Given this list of marker genes Swap70, Polm, Asxl1, Xrcc4, Ccr4, Rnf8, Hmgb1, Supt6, Foxn1, Mcm3ap, Cdkn2b, Fas, Mapk3, Ctc1, Samd9l, Foxj1, Flt3, Rorc, Cyren, Ezh2, Mad1l1, Apc, Lilrb4a, Lig4, Nkx3-2, Cacnb4, Ighd, Cdh17, Smad3 (SMAD family member 3), Shh, Ltb, Dicer1, Sco1, Coa5, Tnfsf11, Nbn, Mapk1, Trp53, Tyr, Pcyt1a, Bcl11b, Psen2, Exo1, Nkx2-5, Cxcl13, Il27ra, Nr5a2, Cfc1, Ccl21a, Flvcr1, Tcf7, Lrrc17, Mir181b-2, Traf3ip2, Icos, H2-T23, Xkr8, Fadd (NCBI Gene Id 14082), Msh3, Ctnnb1, Chaserr, Cd28, Samhd1 (SAM domain and HD domain, 1), Sbds, Nfkb2, Rbm15, Ppp2r3c, Ido1, Lipa, Ptprc, Phlpp1, Slc15a4, Pax1, Jarid2, Ltbr, Foxi3, Kmt5b, Rag2, Hand2, Rc3h2, Prdx2, BC037156, Atad5, Il2ra, Ccnb2, Ripk3, Acod1, Kmt2a, Ada, Exosc3, Marchf7, Tbx1, Foxl1, Rc3h1, Trp53bp1, Carmil2, Raf1, Zbtb1, Map2k1, Ro60, Tlx1, Myb (NCBI Gene Id 97674, myeloblastosis oncogene), Aicda, Cd86, Psen1, Cd40, Braf, Nfkb1, Ephb3, Parp3, H2-M3, Six1, Tgfbr2, Pagr1a, Cd40lg, Gba1, Msh6, Gata3, Tgfb1, Irak3, Fancb, Nuggc, Lef1, Aplf, Ahr, Rnf168, Dcaf1, Tgfbr1, Ccr6, Srf, Rcbtb2 (regulator of chromosome condensation (RCC1) and BTB (POZ) domain containing protein 2), Slc40a1, Prkdc, Rif1, Exosc6, Foxe1, Barx1 (NCBI Gene Id 12022, BarH-like homeobox 1), Pdpn (NCBI Gene Id 14726), Tbx21, Il15, Icosl, Yy1, Lmo4, Pcid2, Ikzf1, Tnfsf13, Mir181b-1, Polb, Fgf3, Foxp1, Cxcr5, Aire, Havcr2, Slc46a2, Sanbr (NCBI Gene Id 71675), Tcf21, Cblb, Cited2, Adar, Ercc1, Ctnnbl1, Lilrb4b, Lta, Polq, Nhej1, Pbx1 (NCBI Gene Id 98516), Hes1, Adrm1, Tox, Six4, Tnfsf4, Pkn1, Hspd1, Atm, Stat5b, Paxip1, Bcl2, Foxp3, Adam17 (NCBI Gene Id 236174), Fam210b, Batf, Il7r, Onecut1, Nfkbiz, Id2, Ret, Itch, Lyn, Bcl6, Bcl3, Bmncr, Zmpste24, Ccr7, Tet2, Cd248, Stat5a, Tnfaip3, Pms2, Nfatc3, Mad2l2, Mlh1, Cd2ap, Pitx2, Lrp5, Runx1, C3ar1, Shld1 (NCBI Gene Id 73747), Cacna1c, Il4, Ung, Fgf10, Ifng (interferon gamma), Msh2, Rag1, Mafb, Artn, Map2k2, Spns2, Bcl2l11, Crkl, Hoxb4, Cd3e, Hoxa3, Mir188, Hmces, Shld3, Abl1, Tnfrsf11a, Dclre1c, Kmt5c, Jak3, Tfrc, Epb42, Pdcd1, Tcf3, Stat6, Shld2, Nkx2-3, Xrcc6, Nsd2, Il2, Clcf1, Ndfip1, here is a description of the gene set: The process whose specific outcome is the progression of an organismal system whose objective is to provide calibrated responses by an organism to a potential internal or invasive threat, over time, from its formation to the mature structure. A system is a regularly interacting or interdependent group of organs or tissues that work together to carry out a given biological process. Mouse Gene Set: GOBP_IMMUNE_SYSTEM_DEVELOPMENT studied in species Mus musculus